Given this list of marker genes TAC1, CRH, GAL, GHRL, ECRG4, GALR1, here is a description of the gene set: Human Gene Set: GOBP_POSITIVE_REGULATION_OF_GLUCOCORTICOID_SECRETION species: Homo sapiens Any process that activates or increases the frequency, rate or extent of glucocorticoid secretion.